Given this list of marker genes APLNR, RYK, COL11A2, XIST, RAB3B, TCF7L1, GLYR1, PTPRK, CIC, LIN9, PLP1, MX1, SLC35D1, GAS8, H1-5 (NCBI Gene Id 3009), ZFYVE16, CELSR1, TACSTD2, NAPSA, PARM1, CCL13, BCL3, DNAJB5, NVL (nuclear VCP like), ROGDI, LY86 (NCBI Gene Id 9450), H19, FABP6, CMTM4, HLA-C, ACTL6B, GSTM3, MPEG1, LIPE, CD34, ADAM23 (NCBI Gene Id 8745), MRPL49, NKX1-2, AGFG1, CRLF1, ELK4, C5, ARAP3, HSPB8, IFIT1B, TCN2, GATA1, TRH, KLC4, SDC1, CAPN3, JUP, FOXD2, HASPIN, HEMGN, ZNF777, EEF1A2, PDCD1, NHSL2, CLDN7 (claudin 7), TCF20, HSD11B2, FKBP10, KHDC1L, DEGS2, MIPOL1, CSRP2, NAP1L4, FXR2, CLEC11A, CTLA4, SLC3A1, ADGRE5, CELA1, NCAM1, TMEM266, ITGAX, ZNF746, FABP4, RAB3A, SCMH1, MDFIC, NMT2, GJB5, SOCS3, FLT3, ABCC6 (ATP binding cassette subfamily C member 6), SBF2 (NCBI Gene Id 81846), PRKAR2A, CD4, ZMIZ2, PTTG1, LTBP4, IRGM, SEMA6C, TST, AHR, CD5L, SH3BP5, HPS1, SLC25A10, IGF2, TRAIP, PBX3, CHRNB1, ZNRF1, DDR2, BBLN, CA3, SNORC, TNNC2, PLK3, MCM6, ANXA1, SMPD2, COL4A1, HRK, C1QTNF12, NPDC1, NPAS1, DHFR (dihydrofolate reductase), NFKBIA, CSAD, LPL, AKAP4, ZNF106, BEX1, CD59, CKAP4, IL15, RARRES2, GNAQ (G protein subunit alpha q), NFKB2, SOX4 (NCBI Gene Id 6659), PRPH, ARL4D, THRSP, INSR, LPAR1, CD81, MR1, CAMK2A, STAG1, CDS2, PITX1, ANGPTL2, N4BP1, ACOD1, PAX2, ELF3, IFI27L2, CD79A, SCN7A, SPSB1, APC, GRIA4, ZNF213, COP1, MGP, COL26A1, ITGAV, EHF, CIT, RAG2, KIT, PTMS, TWIST2, ADORA2A, INPP4A, DAB2IP, TAP1, IKZF4, PAPOLA, TNFRSF9, PVALB, CNIH2, ATP2B2, HCN3, IFIH1, ADAM19, GGCX, PHOSPHO2, UGP2 (UDP-glucose pyrophosphorylase 2), GMIP, ADCY4, MAP3K7, CD200, NEURL4, GSC, RBP1, PCGF2, SHBG, BPHL, CSF2, MYO1D, OPN1LW, PTPRJ, GPR162, VTN, TSG101, here is a description of the gene set: studied in species Homo sapiens Genes up-regulated in double positive thymocytes: wildtype versus TCF12 knockout. We wanted to test the role of mammalian E proteins E2A and HEB in the development of T cells. Using a conditional deletion system in which these proteins are deleted at the DP stage of T cell development, we compared DP thymocytes deficient for E2A, HEB or both to wild-type thymocytes Human Gene Set: GSE19923_WT_VS_HEB_KO_DP_THYMOCYTE_UP from publication D'Cruz LM, Knell J, Fujimoto JK, Goldrath AW (PMID 20154672)